Given this list of marker genes Timeless, Dgcr8, Dscc1, Uxt, Zc3h11a, Ino80b, Aff1, Setd1b, Snrpc, Snrpb, Stn1, Xbp1, Cstf2t, Seh1l, Mafg, Cbx2 (NCBI Gene Id 12416), Senp3, Prpf8, Yy1, Ppihl (NCBI Gene Id 676493), Ddx39b, Cops9, Ercc5, Cry2, Rad51c, Xrcc6, Men1, Thrap3, Ptges3-ps, Prkrip1 (Prkr interacting protein 1 (IL11 inducible)), Taf9b, Nckipsd, Stat6 (NCBI Gene Id 216450), Ing3, Elp2, Dhx40, Snrnp40, Nelfcd, Prdm4, Kat2a, Cebpe, Actb, Hoxb9, E2f4, Pes1, Arnt, Wwox, Terf2ip, Mlx, Cwf19l1, Ss18l1, Plcg1, Nsd1, Rfc5, Faap20, Amotl1, Nxt2, Exosc8, Tcf7l2, Hspa1l, Ik (NCBI Gene Id 24010), Irf9, Cwc22rt4, R3hcc1l, Myc, Eaf1 (NCBI Gene Id 74427), Wdr82, Sf3a1, Atp5f1a, Runx1, Gtf2a1, Supt6 (NCBI Gene Id 75730), Chrac1, Ctnnbl1, Polr1d, Rbmyf6, Dnttip1, Nolc1, Jdp2, Kansl1, Tra2b, Chmp1b, Rnf2, H3f4, Med12l, Chmp4c (NCBI Gene Id 74324), L3mbtl1, Bcl11a, Tbl1xr1, Exosc9, Sap18b, Fancg, Ranbp1, Tcf15, Nono, Nop10, Orc1, Atf5, Srcap, Yju2b, Trrap, Polr2d, Nfe2l3, Chmp1a, Smarce1, Wdr3, Hnrnpu, Paf1, Jup, Ring1, Polr3e, Nup214, Snrpn, Supt4b, Cwc22rt5, Batf2, Elob, Bclaf3, Ptbp2, Ppie, Rbm44, Znhit1, Polr1e, Sap18, Dpf3, Pip5k1a, Csnk1a1, Rnmt, Atf7, Ttf2, Isy1, Zmat5, Tle3, Pcgf6 (NCBI Gene Id 71041), Rbmxl2, Kdm6b, Ino80c, Larp7-ps, Polr2c, Cenps, Satb2, Bmal2, Babam2, Smndc1, Tcf12, Hdac10, Anapc15, Kdm3a, Med17, Rbx1, Ube2c, Cwf19l2, Uvrag, Nat10, Rfxank, Clns1a, Crem, Fancl (NCBI Gene Id 78872), Ints6, Ino80, Psmc5 (protease (prosome, macropain) 26S subunit, ATPase 5), Polr1g, Med21, Med30, Foxo3, Snrnp200, Orc6, Gata4, Znfx1, Cpsf1, Ran, Mre11a, Nup133, Ccnh, Dhx38, Gar1, Ccdc9, Lef1, Gtf2f2, Smarcc2, Rbbp8, Jmjd1c, Suv39h1, Tbx18, Ccnl1, Usp22, Sall1, Pcid2 (NCBI Gene Id 234069), Bard1, Syf2, Pola2, Sarnp, Snrpg (small nuclear ribonucleoprotein polypeptide G), Wrap53, Baz1b, Atf3, Ubqln4, Rbmyf9, Cxxc1, Sem1, Kdm6a, Abraxas1, Anapc5, Ercc4, Suds3, Batf (NCBI Gene Id 54359), Chmp7, Luc7l, Gtf2h4, Runx3, Rbbp7, Nrip1, Grap, Mis18bp1, Smad3, Smarca1, Rara, Ncoa6, Cpsf4, Hmgxb4, Rbm8a, Myo1c, Ddx41, Prkdc, Rcor2, Rnf113a1, Ascl4, Ccnt2, Ezh2 (enhancer of zeste 2 polycomb repressive complex 2 subunit), Mms22l, Cdc5lrt10, Thra, Brd4, Thrb, Ice2, Ldb1 (LIM domain binding 1), Phf12 (NCBI Gene Id 76807), Phc1, Nutf2, Tmod1, Alyreffm1 (NCBI Gene Id 75257), Snrnp48, Ncoa1, Snrpa, Dcaf1, Snrpe, Rbm47, Polr3g, Rpp40, Ssrp1, Ranbp17, Smarca2, S100a10, Polr2j, Zfp830, Brd8, Anapc2, Med26, Ercc3, Rnpc3, Cript, Rfxap, Kdm3b, Ccnk, Pola1, Snw1, Htatsf1, Xrcc3, Hspa8, Sirt1, Cops5 (COP9 signalosome subunit 5), Rxrb, Supt16, Prmt5, Syncrip, Mafb, Prpf19, Ints5, Actl6a, Wdr12, Actl6b, Crcp, Akap17b, Ep400, Srsf1, Hnrnpc, Eif5a, Mad1l1, Pnn, Nelfe, Uba2, Mxd3, Zc3h3, Ddx46, Setd1a, Tead2, Gtf2h3, Ncoa2, Cbx8, Rbm42, Setd5, Ints6l, Anapc15-ps, Polr3c, Dpf2, Kmt2d (NCBI Gene Id 381022), Abraxas2, Gtf2h1, Nr1h3, Rbmy, Xrcc1, Sp100, Gtf2e2, Dbp, Dpf1, Gle1, Wdr6, Mx1, Atxn7l3, Taf1b, Tead1, Pasd1, Ddx5, Upf1, Ino80e, Junb, Nudt21, Cdk2ap1, Ncor1, Samd11, Epb41l2, Xpo4, Xrcc4, Mad2l2, Aff3, Nelfb, Drap1, Alyreffm10, Med19, Gtf2b, Sec13, Lin52, Chmp2a, Bmal1, Lmo4, Gatad2b, Mideas, Tert, Hand1, Chtf8, Rpp21, Cstf2, Sun2, Cops7a, Pabpc1, Brca1, Ppil1, Prim1, Adnp, Rheb, Ranbp2, Cops8, U2af1, Med29, Khdc4, Tuft1, Mecom, Cltc, Kmt2c, Nup35, Atrip, Pcgf1, Med20, Srsf2, Myocd, Tdrd3, Stat5a, Stat1, Mcm2, Ybx1, Lsm10, Hoxb5os, Sfr1, Ppih, Pwp2, Snrpb2, Hltf, Slbp, Bop1 (NCBI Gene Id 97992), Tada3, Rangap1, Eri1, Ube2i, Cbx6, Bcl7c, Taf1c, Cwc15, Ppwd1, Mcm7, Kash5, Bin1, Tut1, Med16 (NCBI Gene Id 216154), Arid4b, BC005624, Thoc6 (NCBI Gene Id 386612), Mcm3, Smad1, Mbd2, Chd4, Rad23b, Rad1, Noc4l, Srek1, Topbp1, Ints15, Ctr9, Rxra, Exosc3, Mcm5, Ube2s, Mllt1, Cwc22rt2, Bmyc, Bcl11b, Cbx7, Thoc2l, Pcf11, Gpkow, Hus1b, Prpf4, Myh9, Epop, Tra2a, Pcgf2, Brd7, Rybp, Jarid2, Snrpd1, Smad6, Slc5a8, Brca2, Cdk9, Bcl7b, Cecr2, Mrnip, Cstf1, Cops2, Hspa5, Alyref2, Ddx20, Brip1, Txnl4a, Thap11, Wdr83 (WD repeat domain containing 83, NCBI Gene Id 67836), Wdr5b, Rpp38, Hmga1, Brcc3dc, Cwc27, Rbmx2 (RNA binding motif protein, X-linked 2), Lsm6, Acd, Rsf1, Hint1, Sun3, Ess2, Ints4, Parp11, Asxl3, Asxl1, Cdc27, Lsm2, Senp2, Tfdp2, Imp4, Nipbl, Chd8, Rbbp5, Pcna, Hspa1a, Trp53, Bclaf1, Cdc5l, Cdc20b, Polr3k, Tespa1, Bptf, Lig4, Cdk8, Med18 (NCBI Gene Id 67219), Eif4a3l1 (eukaryotic translation initiation factor 4A3 like 1), Bahd1, Samd7, Luc7l2, Smu1, Bod1, Cetn3, Ruvbl1, Stat5b, Ercc1, Mybbp1a, Pou2f1, Rbmyf1, Crebbp, Chmp4b, Taf1d, Cdc20, Polr1a, Dr1, Smarca4, E2f2, Xrcc5 (NCBI Gene Id 98297), Syne3, Wac, Clock, Gtf2e1, Rela, Sap30, Med10, Aff4, Polr3a, Cdc5lrt9, Nfyb, Rrp8, Tcf3, Cdc5lrt1, Rbmyf3, Sinhcaf, Tfpt, Stat3, Rbbp4, Anxa2, Mga, Pms1, Zmat2, Leo1, Arid2, Tcea1, Cpsf3, Ercc2, Ddx11 (DEAD/H box helicase 11), Sf3b5, Ss18, Mfap1a, Taf7, Chtf18, Mx2, Crx, Sfpq, Paxip1, Syne4, Nup107, Flna, Ddx21, Msh2, Nup62, Sf3a3, Noc2l, Polr2i, Gnl3l (NCBI Gene Id 237107), Cdk2ap2, Cdc5lrt7, Pot1b, Med14, Smg7, Sin3a, Ppil3, Hyal2, Eif4a3l2, Mau2, Ezh1, Dhx8, Ints9, Chaer1, Rae1, Hnrnpa1, Atxn7, Fip1l1, Pot1a, Aar2, Terf2 (telomeric repeat binding factor 2), Evx1os, Marveld3, Pole3, Snrpd3, Gemin5, Rcor1, Ints10, Scnm1, Gtf2h5, Anapc16 (NCBI Gene Id 66363), Orc5, Snrnp27, Sap30l, Polr2g, Mcm3ap, Cirbp, Med9, Phf10, Jun, Nxf1, Syne2, Supt5, Phf21a, Havcr2, Lrwd1 (NCBI Gene Id 71735), Brms1l, Snrpa1, Nhej1, Pcgf3, Ints14, Nutf2-ps1, Tcf4, Bicd2, Mtrex, Hexim1, Crnkl1 (NCBI Gene Id 96998), Nelfa, Nup153, Ino80d, Taf2, Nr5a2, Xpc, Mbd3, Tet1, Tep1, Dnajc17, Gins1, Cdc5lrt5, Stat2, Phc2, Ell2, Pagr1a, Prpf38a (PRP38 pre-mRNA processing factor 38 (yeast) domain containing A), Nfe2l2, Aqr, Rbmxl1, Taf5l, Med1, Kpna4, Rbm3, Elobl, Hlf, Cbx5, Lsm5, Rrp7a, Hipk2, Max, Syne1, Casp8, Nol11 (NCBI Gene Id 68979), Rpp30, Taf13, Usp39, Phf20, Cpsf6, Magohb, Bmi1, Kpnb1, Asxl2, Zfp143, Cdc5lrt4, Gtf2h2, Xab2, Anapc1, Aebp2, Nabp2, Gemin2, Cops3, Upf3b, Taf4, Magoh, Pou4f1, Polr2f, E2f8, Cpsf4l, Chmp2b, Swi5, Carm1, Dmap1, Ppil2, Polr1f, Bod1l, Chtop, Bicral, Foxh1, Bach1, E2f6, Zfp335, 0610010K14Rik, Pelp1, Nup188, Helb, Med27, Baz1a, A1cf, Ints3, Snrpert, Tonsl, Slu7, Nup43, Smarcc1, Arfgef1, Rtf1, Pop1, Cebpz, Morf4l1, Basp1, Wbp4 (WW domain binding protein 4), Spag4, Bccip, Fancc, Chmp5 (NCBI Gene Id 76959), Rbm28, Cpsf2, Plrg1, Exosc5, Atf4, Lsm11, Atf2, Lin54, Ing1, Msh6, Alyreffm5, Cebpg, Brcc3, Ints11, Ercc8, Alyreffm4, Uty, Rfc2, Smarcd3 (SWI/SNF related, matrix associated, actin dependent regulator of chromatin, subfamily d, member 3), Tex24, Bach2, Kmt2a, Snrnp25, Tsen34, Ints1, Pom121l2, Actr8, Exosc1, Heatr1, Utp6, Eloc (NCBI Gene Id 98484), Hnrnph1, Exosc4, Pole, Hdac11, Gins3, Gatad2a, Fosl2, Med24, Arid4a, Cdc16, Taf6, Nup54, Smarcb1, Cwc22rt7 (NCBI Gene Id 668115), Nup155, Nvl, Nufip1, Nup37, Utp18, Yy2, Nup62cl, Trim37, Rnf113a2, Med7, Rad51, Brms1, Rpa3, Nbn, Srrm2, Ascl3, Fancb, Ints12, E2f1 (NCBI Gene Id 13555), Supt4a, Deaf1, Hr, Scaf8, Adar, U2af2, U2af1l4, Cetn2, Pou2af1, Mtf2, Exosc2, Med23, Hsp90ab1, Ruvbl2, Cdc26, Rere, Mxi1, Thoc2, Smarcd1, Alyref, Bicra, Luzp1, Ahctf1, Gon4l, Clmn, Sae1, Polr2k, Hdac3, Cdk7, Tcf7l1, Snrnp70, Rad51d, Trerf1, Zrsr2, Rybp-ps, Rbm41 (RNA binding motif protein 41), Casc3, Uchl5, Sf3a2, Nxt1, Chmp1b2, Prpf18, Ercc6 (excision repair cross-complementing rodent repair deficiency, complementation group 6), Smad2, Faap100, Eif4a3, Bcl9l, Csnk2b, Bcor (NCBI Gene Id 76075), Ascl1 (achaete-scute family bHLH transcription factor 1), Cdc40, Dqx1, Tent4a, Imp3, Per2, Cd2bp2, Pbrm1, Atf1-ps, Taf8, Shmt2, Cwc22, Bcl9, Rb1, Sf3b2, Lig3, Ints7, Dis3, Rad9a, Gins2, Hus1, E2f5, Ncoa3, Hnrnpm, Smad4, Mcm4, Zbtb7a, Maf, Ndc1, Bcl7a, Hcfc2, Csnk2a2, Atf6, Nfatc2, Lgals3, Ube2srt, Cenpx, Larp7, Med31, Smad7, Alyreffm8, Chd3, Prpf40a, Brd9, Mlh1, Cdc5lrt6, Pop5, Ctnnbip1, Ramac, Bcas2, Dynll1, Zfp541, Aff2, Med28 (mediator complex subunit 28), Nfrkb, Orc2, Orc3, Ogt, Gtf2a2, Fos, Phc3, Prpf38b, Xrcc2, Exosc7, Smg5 (SMG5 nonsense mediated mRNA decay factor), Dpy30, Mpnd, Wdr74, Med15, Pole2, Gcfc2, Mis18a, Pym1, Grb2, Rbm8a2, Cdk13, Mta1, Rbm5, Apobec1, Nr1h5, Esrrb, Taf5, Ddx23, Mnat1, Polr2b, Txnl4b, Xpot, Ascl5, Arid1b, Polr2m, Gps1, Thoc5, Tbp, Paxx, Scml2, Taf9, Ssu72, Nxf2, Tbl1x, Polr3gl, Exosc6, Hnrnpab (heterogeneous nuclear ribonucleoprotein A/B), Neurod1 (NCBI Gene Id 18012), Thoc1, Kat7, Tex10, Ncl, Creb1, Anp32e, Med11, Rbm48, Mcm6, Slx1b, Amot, Rfc4, Tinf2, Pold3, Nxf7, Smarcd2, Polr3f, Med12, Cstf3, Alyreffm7, Bap1, Pcgf5, Phf5a, Med22, Cwc22rt1, Nup42, Nr1h2, Rpa1, Pex2, Zc3h8, Nup58, Tle4, Snu13, Cdk2ap1rt, Dek, Ctnnb1, Hdac7, Chmp6, Polr1c, Zfp42, Polr1b, Nabp1, Zcchc8, Eaf2, Cwc22rt6, Ncor2, Hdac6, Etv3 (NCBI Gene Id 99611), Tex16, Cdc23, Lin37, Cdc5lrt8, Prpf6, Hdac1, Med4, Crebzf, Actr6 (NCBI Gene Id 67019), Tle1, Luc7l3, Lsm7, Eny2, Fancm, Sf3b6, Pbx1, Yap1, Mybl2, Taf10, Lsm8, Prpf3, Chd5, Cdc73, Zc3hc1, Polr3h, Taf6l, Hnrnpk, Myzap, Polr1h, Hnrnpa3, Prpf4b, Nup88, Sap130, Ing2, Anapc7, Rad51b, Ddx42, Hnrnpf, Yju2, Hdac2, Dnmt3l, Arid1a, Med13, Taf1, Ten1, Npas2, Mfap1b, Dock7, Cops6, Flot1, Cwc25, Zcchc7, Sla, Babam1, Aurkaip1, E2f3, Uimc1, Srrm1, Vdr, Rcor3, Myb (myeloblastosis oncogene), Gtf2f1, Pold4, Rfc3, Anapc11, Sf1, Mlxipl, Ccnc, Xpa, Smarca5, Snrpf, Kdm2b (NCBI Gene Id 30841), Suz12, Maff, Clp1, Ppargc1b, Faap24, Sympk, Actr5, Bud13, Ascl2, Kat8, Pygo2, Rbm17, Nkx2-5, Nol6, Polr2a, Snip1, Ints2, Med25, Stat4, Zfp217 (NCBI Gene Id 99438), Rxrg, Med8, Lbr, Orc4, Anapc4, Slx4, Cbfb (NCBI Gene Id 12400), Ppp1r8, Elp4, Dbf4 (NCBI Gene Id 27214), Tpr, Skp1, Tssc4, Mphosph10, Tsen54, E2f7, Birc5, Aaas, Snrnp35, Jund (NCBI Gene Id 16478), Mad2l1, Cdc45, Dydc1, Atr, Cbx4, Hdac5, Pold2, Tsen2, Tbpl1, Pms2, Sugp1, Baz2a, Nup50, Nfkb1, Fancf, Taf11, Sun1, Fanca, Cebpb, Fzr1, Brd1, Csnk2a1, Elof1, Rbm22, Lat, Ell, Nup205, Cops4, Rps3, Atf1, Eloa, Alyreffm11, Themis, Upf2, Cfdp1, Dhx35, Prpf40b, Tbx15, Med6 (NCBI Gene Id 69792), Utp4, Pdcd7, Phf19, Hdac8, Dhx32, Terf1, Pole4, Anapc10, Mcrs1, Mta3, Mlxip, Dhx15, Dhx16, Hnrnpa2b1, Batf3, Cdkn1a, Cdk12, Nhp2, Sin3b, Nup210l, Vps4a, Rbmx (RNA binding motif protein, X chromosome), Alyreffm6, Drosha, Mxd4, Nop14, Atf6b, Lsm4, Exosc10, Thoc3, Polr2h, Pop7, Gins4, Mxd1, Mta2, Xpo7, Wdr5, Prpf31, Cebpa, Pparg, Ptges3, Hdac4, Gtf2a1l, Pom121, Ash2l, Fosl1, Bub3, Tnks, Terb1, Mphosph6, 9630013A20Rik, Phf1, Med13l, Rad9b, Kmt2b, Nfya, Trim28, Alyreffm3, Ahr, Tfip11, Cops7b, Polr2e, Armc7, Nup210, Ddit3, Inip, Tfdp1, Tipin (timeless interacting protein), Hcfc1, Supt3, Creb3, Taf1a, Sart1, Ints13, Wdr18, Taf3, Bub1b, Gpatch1, Pold1, Sart3, Prdm8, Bud31, Nup98, Rad50, Polr3b, Nup85, Chmp3, Gm7324, Alyreffm9, Nr1h4, Nxf3, Ccnt1, Mllt3, Fanci, Anapc13, Hnrnpr, Sf3b1, Ccdc12, Nup93, Nup160, Acin1, Sun5, Smarcal1, Taf7l, Cwc22rt3, Smad9, Msh3, Wdr33, Tent4b, Nfe2, Ice1, Hif1a, Taf4b, Cbx3, Las1l, Cpsf7, Ramacl, Nfyc, Frg1, Polr2l, Eed, Ctc1, Vps4b, Polr3d, Prim2, Nr5a1, Cactin, Rpa2, Api5, Kat5, Cebpd, Hdac9, Rfx5, Raly (NCBI Gene Id 99057), Kmt2e, Skic8, Tcf7, Snrpd2, Wdr36, Fance, Thoc7, Mepce, Dkc1, Nfil3, Sf3b3, Prpf39, Hmg20b, Taf12, Eftud2, Lsm3, Smg6, Ubap2l, Ints8, Ell3, Sf3b4, Zcrb1, Smad5, here is a description of the gene set: Mouse Gene Set: GOCC_NUCLEAR_PROTEIN_CONTAINING_COMPLEX species: Mus musculus A stable assembly of two or more macromolecules, i.e. proteins, nucleic acids, carbohydrates or lipids, in which at least one component is a protein and the constituent parts function together in the nucleus.